Given this list of marker genes ASH2L, CHTF8, TRAF3, ZNF75A, MGAT4A, FOXG1, ADAMTS19, LDLRAD4, KCTD15, NSF, SEC62, AZI2, ASB15, DNAJB7 (NCBI Gene Id 150353), ARMT1, HNRNPH1, CD24, TASOR, ACAD10, ANK3, HNMT, TSPAN8, PAGR1, LRRC28, TTC14, SEC23A, USP6NL, FAR1, UVRAG, TMEM38B, BORCS7 (NCBI Gene Id 119032), RSU1, LSM14A, SLITRK5, HNRNPF, NOA1, LIN7C, FLRT3, ZNF266, REV3L, DPH6, ZEB2, DUSP19, VPS36, TLCD4, USP30, FAM171B, RIC3, TMEM170B, ZNF326 (zinc finger protein 326), APLN, ZNF782, P4HB, TFAP2A, MAPK14, CPEB2, VPS52, CELF2, DDIAS, UHRF1, CYLC2, SNX2, STRBP, SEC24D, DDX6 (NCBI Gene Id 1656), IMPA1, MTDH, ARMC1, RBM11 (NCBI Gene Id 54033), SGCZ, MTERF3, MKX, TAB2, SELENOF (NCBI Gene Id 9403), ATP1B1, GPC6, SPPL3, NABP1, USP31, IL6ST, DCLK1, ICE1, SGCD, HECTD2, TRIP4, ERCC6L2, MARF1, ZNF117, SLC35A3, SLC30A7, CAPRIN1, NR1I2, MMGT1, MAP4, SPIN1, CHKA, TXNRD1, TSGA10, RAB3IP, AFF3, RFWD3, MMADHC, CSTF2, PPP2R5E, MAP3K21, ERICH1, DPP10, VCL, MEF2A, ANKRD6, ZBTB20 (NCBI Gene Id 26137), MRPS33, CLCN4, here is a description of the gene set: Human Gene Set: MIR124_5P species: Homo sapiens Genes predicted to be targets of miRBase v22 microRNA hsa-miR-124-5p in miRDB v6.0 with MirTarget v4 prediction scores > 80 (high confidence targets). from publication Chen Y, Wang X (PMID 31504780)